The following is a description of a gene set: The movement of a lymphocyte within the lymphatic system into lymphoid organs such as lymph nodes, spleen or Peyer's patches, and its subsequent positioning within defined functional compartments such as sites of cell activation by antigen. Mouse Gene Set: GOBP_LYMPHOCYTE_MIGRATION_INTO_LYMPHOID_ORGANS species: Mus musculus, and this is the list of marker genes: Ext1, Ccr7, Nedd9, Lrp12, Crtam, Wnk1, Fut4, Fut7, Artn, Cadm1